The following is a description of a gene set: Genes down-regulated in comparison of dendritic cells (DC) stimulated with LPS (TLR4 agonist) at 1 h versus DC cells stimulated with Pam3Csk4 (TLR1/2 agonist) at 1 h. studied in species Homo sapiens mouse primary BMDCs were stimulated with tlr ligands and gene expression changes were profiled on Affymetrix arrays Human Gene Set: GSE17721_LPS_VS_PAM3CSK4_1H_BMDC_DN from publication Amit I, Garber M, Chevrier N, Leite AP, Donner Y, Eisenhaure T, Guttman M, Grenier JK, Li W, Zuk O, Schubert LA, Birditt B, Shay T, Goren A, Zhang X, Smith Z, Deering R, McDonald RC, Cabili M, Bernstein BE, Rinn JL, Meissner A, Root DE, Hacohen N, Regev A (PMID 19729616), and this is the list of marker genes: SEMA3E, NDRG1, PPP1R10 (NCBI Gene Id 5514), MEF2B, PRMT7, TDRD7, CD70, KRTAP8-1, WDR81, GLB1, HPGDS, NAPG, PLSCR1, TMBIM6, ZNRF1, SLC22A25, RAP1GDS1 (Rap1 GTPase-GDP dissociation stimulator 1), RYR1, UTP20, FAM20C, NFKBIZ, HIP1R, FAS, CALB1, PIK3CA, CDKN2B, ALPK2, GPC1, SLC41A1, GTF2I, FASLG, ZFP92, ZC3H12C, ANPEP, IL17RD, WDR33, ITGB1, LRP2, NHSL1, RNF111, CDK5R1, IRF8, MET, MTF1, TAC1, AARD, FHOD3, HNRNPLL (NCBI Gene Id 92906), PARP8, APAF1 (NCBI Gene Id 317), MIB1, VPREB3, ANKRD33B, CDH2, RNF19A, PTGR3, EDN3, DNAJC13, ARHGEF12, MECP2, TMEM39A, GATA2, CD80, FRMD6, ARRDC1, NCK2, MAT2A, DNAJB5, CSNK1G2, NUDT9, RNF14, RASA2, ZSWIM9 (NCBI Gene Id 374920), KLC3, NFKBIA, DUSP16, EPB41L2, FAM53C, ATF4, EIF3C, ST6GAL1, CADPS2, SLC23A2, TAOK1, FOSL2, CHMP1A, PIM3, LFNG, ABHD3, NCF2, CAMKV, VANGL2, ASL, IFNGR1, PDE9A, AQP7, SOWAHC, OTX2, ICAM1, PARP12, ZNF598, NKX2-1, PAX1, PTGS2, PDGFRB, LIN9, CBX4, ADCY8, APBB1IP, GPD2, USP10, EPOR, IL1R1, TAF1C, NR4A1, PIGR (polymeric immunoglobulin receptor), BRD2 (bromodomain containing 2), CACNA1H, TMEM229B, JUNB, TBC1D8B, BAZ1B, VCAM1, CDKN1A, FN3K, RING1, KLF17, CHKA, MCAM, DAPP1, EPHA3, SRXN1, XIRP1, PDE1B, MAPK6 (mitogen-activated protein kinase 6), TYRP1, CLASRP, ZNF354A, DHCR24, PUF60, CYP21A1P (cytochrome P450 family 21 subfamily A member 1, pseudogene, NCBI Gene Id 1590), BMP6, OSBP, ABHD17C, TNIP1, DPEP3, ZC3H12A, IRAK4 (interleukin 1 receptor associated kinase 4), HORMAD1, MAP3K8, ADORA2B, MYO1C, PAH, SLC11A1, SCML4, PNPO, SBDS, KRT8, CELA2A, SCAF4, KCNN3 (potassium calcium-activated channel subfamily N member 3), TRPC7, UBIAD1, ITPRID2, GADD45B, SKIL, XAB2, UGDH, POLG, KDR, CCND2, DERL3, PRDM1, DNMT1, SPRY1, SORT1, DGKG, CXCL2, GPN2, B3GNT2, PECAM1, TSC22D1, MAPKBP1, USP11, TRIM2, BIRC3, UBE2J2, MTHFD2, FSTL1, BRCA2, NADK, SLC7A6, CEBPB, UBXN4, ERN1, ARHGAP1, TRIM8, WNT11, TNFAIP1